The following is a description of a gene set: Human Gene Set: GOBP_COPPER_ION_TRANSPORT The directed movement of copper (Cu) ions into, out of or within a cell, or between cells, by means of some agent such as a transporter or pore. studied in species Homo sapiens, and this is the list of marker genes: FKBP4, STEAP2, ATP7B, SLC11A2, CUTC, SLC39A11, SLC31A1, STEAP4, MMGT1 (NCBI Gene Id 93380), SLC31A2, STEAP3, HEPHL1, ATP7A, COX17, ATOX1, SLC46A3